Given this list of marker genes PGM1, here is a description of the gene set: Reactome Pathway: Defective PGM1 causes PGM1-CDG studied in species Homo sapiens part of: Diseases associated with glycosylation precursor biosynthesis Phosphoglucomutases 1 and 2 (PGM1, 2) are involved in the cytosolic biosynthesis of nucleotide sugars needed for glycan biosynthesis, specifically, the isomerisation of glucose-6-phosphate (G6P) into glucose-1-phosphate (G1P). Defects in PGM1 can cause congenital disorder of glycosylation 1t (CDG1t, now known as PGM1-CDG; MIM:614921), a broad spectrum disorder characterised by under-glycosylated serum glycoproteins. CDGs result in a wide variety of clinical features such as defects in nervous system development, psychomotor retardation, dysmorphic features, hypotonia, coagulation disorders, and immunodeficiency.